Given this list of marker genes Lrrc17, Fgfr2, Abl1, Nf2, Bcl2, Bmp2, Lrp5, Plxnb1 (plexin B1), Axin2, Igf1r, Nell1, Fignl1, Fbln5, Tmem119, Smad3, Npr3, Ltf, Rhoa, Sfrp1, Tnn (NCBI Gene Id 329278), Gsk3b (NCBI Gene Id 98033), Kcnq1ot1, Itgav, Grem1, Cthrc1, Junb, Hpse, Mus81, Osr2, Sox8, Ccn1, Eif2ak2, Atraid, Mn1, Itgb3, Ahr, Gata1, Ift80, here is a description of the gene set: The multiplication or reproduction of osteoblasts, resulting in the expansion of an osteoblast cell population. An osteoblast is a bone-forming cell which secretes an extracellular matrix. Hydroxyapatite crystals are then deposited into the matrix to form bone. Mouse Gene Set: GOBP_OSTEOBLAST_PROLIFERATION species: Mus musculus